Given this list of marker genes Tango2, Dgcr2, Enho, Rtn4r, 2510002D24Rik, Dgcr6, Comt, Gp1bb, Prodh, Ufd1, Slc25a1, Ranbp1, Cldn5, Zdhhc8, Foxn3, Mrpl40, Hira, Arvcf (NCBI Gene Id 11877), Txnrd2, Trmt2a, Snora74a, Dgcr8, Ess2, here is a description of the gene set: Mouse Gene Set: STARK_HYPPOCAMPUS_22Q11_DELETION_DN species: Mus musculus Genes down-regulated in hyppocampus of mice carrying a hemizygotic microdeletion in the 22q11.2 region. Individuals with 22q11.2 microdeletions show behavioral and cognitive deficits and are at high risk of developing schizophrenia. We analyzed an engineered mouse strain carrying a chromosomal deficiency spanning a segment syntenic to the human 22q11.2 locus. We uncovered a previously unknown alteration in the biogenesis of microRNAs (miRNAs) and identified a subset of brain miRNAs affected by the microdeletion. We provide evidence that the abnormal miRNA biogenesis emerges because of haploinsufficiency of the Dgcr8 gene, which encodes an RNA-binding moiety of the 'microprocessor' complex and contributes to the behavioral and neuronal deficits associated with the 22q11.2 microdeletion. from publication Stark KL, Xu B, Bagchi A, Lai WS, Liu H, Hsu R, Wan X, Pavlidis P, Mills AA, Karayiorgou M, Gogos JA (PMID 18469815)